The following is a description of a gene set: Generalized hyperreflexia Human Gene Set: HP_GENERALIZED_HYPERREFLEXIA species: Homo sapiens, and this is the list of marker genes: SPG7, NADK2, CARS1, GTF2H5, ABCD1, SLC25A12, SLC2A1, GTF2E2, EEF2, MPLKIP, RNF113A, AARS1, TARS1, ERCC2, ERCC3, SLC52A3